Given this list of marker genes METTL3, FGF10, RHOA, GAP43, METRN, CCDC85C, CDH2 (NCBI Gene Id 1000), HES1 (NCBI Gene Id 3280), EMX1, GLI3 (NCBI Gene Id 2737), STAT3, GPR157, METTL14, LEF1, here is a description of the gene set: The process in which neuroepithelial cells of the neural tube give rise to radial glial cells, specialized bipotential progenitors cells of the brain. Differentiation includes the processes involved in commitment of a cell to a specific fate. Human Gene Set: GOBP_RADIAL_GLIAL_CELL_DIFFERENTIATION species: Homo sapiens